The following is a description of a gene set: studied in species Mus musculus Any process that modulates the frequency, rate or extent of assembly of the SNARE complex. The SNARE complex is a protein complex involved in membrane fusion; a stable ternary complex consisting of a four-helix bundle, usually formed from one R-SNARE and three Q-SNAREs with an ionic layer sandwiched between hydrophobic layers. Mouse Gene Set: GOBP_REGULATION_OF_SNARE_COMPLEX_ASSEMBLY, and this is the list of marker genes: Ankrd27, Trim9, Prrt2, Snca, Stxbp6, Septin8 (NCBI Gene Id 20362)